The following is a description of a gene set: studied in species Homo sapiens Human Gene Set: WANG_CISPLATIN_RESPONSE_AND_XPC_UP from publication Wang G, Chuang L, Zhang X, Colton S, Dombkowski A, Reiners J, Diakiw A, Xu XS (PMID 15107491) XPC is an important DNA damage recognition protein involved in DNA nucleotide excision repair. We have studied the role of the XPC protein in cisplatin treatment-mediated cell cycle regulation. Through the comparison of microarray data obtained from human normal fibroblasts and two individual XPC-defective cell lines, genes were identified as XPC-responsive genes in the cisplatin treatment (with a minimal 1.5-fold change) and 297 of these genes were further mapped to biological pathways and gene ontologies. The cell cycle and cell proliferation-related genes were the most affected genes by the XPC defect in the cisplatin treatment. Many other cellular function genes were also affected by the XPC defect in the treatment. Western blot hybridization results revealed that the XPC defect reduced the p53 responses to the cisplatin treatment. The ability to activate caspase-3 was also attenuated in the XPC cells with the treatment. These results suggest that the XPC protein plays a critical role in initiating the cisplatin DNA damaging treatment-mediated signal transduction process, resulting in activation of the p53 pathway and cell cycle arrest that allow DNA repair and apoptosis to take place. These results reveal an important role of the XPC protein in the cancer prevention. Genes up-regulated in fibroblasts with defective XPC in response to cisplatin., and this is the list of marker genes: ADK, MGP, NPC2, HES1, AREG, NCAPD3, FXYD3, HSBP1, FADS1, CCN5, GPX3, PCLAF, CETN2, RFC5, MLH1, ARHGAP4, SLC17A9, AURKA, PICALM, SLC43A3, ZNF502, ITGB3BP, CDC7, INSIG1, FANCG, MXD3, GAGE12F, CD247, RPA3, THBS2, CX3CR1, TMC6, LBR, HSPA5, CFB, ST6GALNAC2, RNF144A, CEACAM6, MZT1, TMSB15A, POLA2, DBI, IGF2BP3, TRIP13, FGB, GALE, PYCR1, GLDC, TM4SF1, PLEKHH1, NCAPD2, H1-2, POLD1, JARID2, DDX11, IGLL5, INTS9, PROS1, PCP2, ATP5MC1, COL18A1, STT3A, MYC, BCAS1, MYEF2, GPC3, HMGB2, PTPRN2, SLC19A1, HEY1, DCK, DYNC1H1, PRSS1, HSP90B1, RNASEH2A, FIGNL1, SEMG1, UBD, MSH6, GTF2H2, CD9, THBS1, CTSC, GSE1, XBP1 (NCBI Gene Id 7494), SEMA3B, PIN4, PMEL, SERPINA1, PPP5C, KRT8, HNRNPA2B1, ANKRD11, ASB9, PGK2 (phosphoglycerate kinase 2), RPN1, PRKX, ASGR1, FDPS, GATA3, SCARB1, ILF2, RGS2, VTN, TARBP1, TOMM40, ATAD3A, F7, FEN1, SLC27A2, MST1, CYP4F3, NUP93, H2AX (H2A.X variant histone), TTLL5, RAD51 (RAD51 recombinase), ANXA3, ZNF589, TFF1, PRKY, KRT14, IGFBP1, MAD2L1, RDH14, SULT1A4, BIRC5, AP1G2, SMC4, KIF22, KRT18, CNTN2, PSMC5 (proteasome 26S subunit, ATPase 5), A2M, KIF21A, PDXK, KIF11, CDH1, G6PC1, CRIPTO, IGF2R, IGDCC3 (NCBI Gene Id 9543), FOXC2, TTN (NCBI Gene Id 7847), GGCT, H2AZ1, APOA2, HCFC1, UBE2C, ITGB7, EBLN2, PRAME, IL32, MANF (mesencephalic astrocyte derived neurotrophic factor), VRK2, ADGRG6, FADS2, TTK, LIG1, COL1A1 (NCBI Gene Id 4970), SLC12A3, CGA, SMARCC1, KIF14, MMP1, RNASE6, BMP5, MGST2, NTS, CEACAM1, HMGCS1, YEATS4, SLC25A20P1, MDC1, TNFSF9, TF, RGR, CDK1, LYN, TELO2 (telomere maintenance 2), LMO2, NDP, GREB1, PAH, CLDN4, IGFBP2